Given this list of marker genes CHAC1, XPOT, ODR4, SNX18, NFIL3, CDCA7L, MAP4K3, SMYD3, USP22, ANGPTL6, ZFAND5, NEPRO, GYS1, KCMF1, RLF, SLC2A1, TSPAN9, CHIC2, LUC7L, BASP1, MT2A, EEIG1, ARL4C, EXOC5, SNHG12, ERO1A, PRELID2, PLEKHA2 (pleckstrin homology domain containing A2), FBXL5, BIRC3, RBM22, SMTNL2, MLLT3, PSENEN, UTP18, ITK, ASNS (asparagine synthetase (glutamine-hydrolyzing)), DIPK2A, ZNF451, PFKP, TRMT10C, C3orf38, NFE2L2, GADD45G, PKP2, CSRNP1, LRP12, ZNF292, VSIR, BANP, FKBP1A, WAPL, GEM, RASGRP1, FOSL2, CCND3, TNF, HSPA9, REXO2, ZMYM2, HBEGF, NDEL1, ALDH18A1, BHLHE40, FBXO30, SLC30A9, RRP1B, PDE4B, KMT5B, PCGF5, GCM2, AGPAT3, SMNDC1, ERRFI1, IL24, P4HA1, JMJD6, BTG3, LTB, RHBDD1, SRM, C1QTNF12, HK2, NDRG1, CARS1 (cysteinyl-tRNA synthetase 1), PIM3, PPP2R2A, SARAF, ARHGAP5, MIPOL1, GALNT6, NIBAN1, FAM204A, NUP50, STC2, HIF1A, ZNF608, PARP6, PPP1R3B (protein phosphatase 1 regulatory subunit 3B), CISH, USPL1, RESF1, ATF4, AQP9, TRIM24, TRIB3, ATF5, ACAP1, PRPF38B, PC, LRATD2, SPRED1, PLCXD1 (phosphatidylinositol specific phospholipase C X domain containing 1), MALT1, MCF2L, PRNP, SLC38A2, NOC3L, NAA16, ITIH5, CYRIB, SENP6, MTMR3, ZFP62, LTA, ATAD3A, HNRNPDL, DDX50, TENT5A, EGLN3, CDK17, SPIN1, HERPUD1, PAXBP1, TENT2, CREBZF, DCUN1D3 (defective in cullin neddylation 1 domain containing 3), ARID5A, SMC5, PFKFB3, KLHDC1, DENND2D, CD300LF, TAFA3, MYC, ATF3, NDFIP2 (Nedd4 family interacting protein 2), LRIG2, ARL14EP, SNHG17, CEP170, CDK6, AARS1, RCN1, EEF1E1, TMEM158, SYCE2, SGF29, SEH1L, RGCC, MOB4, ITGAV, SERTAD2, AFG2A, TPD52, ATG16L1, TNFRSF9, HILPDA, SAR1A, SEC24A, SOCS1, CDKN1A, HBP1, CEBPG, CD53, RCHY1, LIN7C, MARCHF7, FAF1 (Fas associated factor 1), RUNDC3B, C3orf18, DIMT1, SMOX, NOP2, GPBP1, SLC2A3, RNF138, MXI1, CNDP2, AHCYL2, NARS1 (asparaginyl-tRNA synthetase 1), LAMA5, PAPSS1, FNIP1, DDIT3, ETV3 (ETS variant transcription factor 3), DNAJA3, USP27X, TES, SAP30, here is a description of the gene set: We have previously shown that rheumatoid factors (RF) produced by Fas-deficient autoimmune-prone mice typically bind autologous IgG2a with remarkably low affinity. Nevertheless, B cells representative of this RF population proliferate vigorously in response IgG2a/chromatin immune complexes through a mechanism dependent on the sequential engagement of the BCR and Toll-like receptor 9 (TLR9). To more precisely address the role of both receptors in this response, we analyzed the signaling pathways activated in AM14 B cells stimulated with these complexes. We found that the BCR not only serves to direct the chromatin complex to an internal compartment where it can engage TLR9 but also transmits a suboptimal signal that in combination with the signals emanating from TLR9 leads to NF-kappa-B activation and proliferation. Importantly, engagement of both receptors leads to the upregulation of a group of gene products, not induced by the BCR or TLR9 alone, that include IL-2. These data indicate that autoreactive B cells, stimulated by a combination of BCR and TLR9 ligands, acquire functional properties that may contribute to the activation of additional cells involved in the autoimmune disease process. Genes down-regulated in B lymphocytes: CpG oligodeoxynucleotide 1826 versus anti IgM and CpG oligodeoxynucleotide 1826. from publication Busconi L, Bauer JW, Tumang JR, Laws A, Perkins-Mesires K, Tabor AS, Lau C, Corley RB, Rothstein TL, Lund FE, Behrens TW, Marshak-Rothstein A (PMID 18025183) species: Homo sapiens Human Gene Set: GSE6674_CPG_VS_CPG_AND_ANTI_IGM_STIM_BCELL_DN